Given this list of marker genes COL3A1, OLFML2B, COL1A2, COL5A1, FAP, LUM, LOX, SUGCT, COPZ2, COL5A2, AEBP1, SNAI2, NUAK1, LOXL2, COL6A3, GREM1, EPYC, COL11A1 (NCBI Gene Id 317718), COMP, PCOLCE, COL1A1, CRISPLD2, C1QTNF3, MFAP5, EDNRA, RAB31, MMP2, SPOCK1, CTSK, TMEM158, GLT8D2 (NCBI Gene Id 83468), SERPINF1, BGN, MXRA5, MMP11 (matrix metallopeptidase 11), SPARC, FN1, POSTN, THY1, COL10A1, NID2, RCN3, COL6A2, TIMP3, TNFAIP6, ITGBL1, PRRX1, CDH11, ACTA2, PLAU, THBS2, FBN1, ADAM12, LGALS1, LRRC15, PDGFRB, NTM, SULF1, VCAN, SFRP4, DCN, NOX4, ASPN, INHBA, here is a description of the gene set: studied in species Homo sapiens Human Gene Set: ANASTASSIOU_MULTICANCER_INVASIVENESS_SIGNATURE from publication Anastassiou D, Rumjantseva V, Cheng W, Huang J, Canoll PD, Yamashiro DJ, Kandel JJ (PMID 22208948) BACKGROUND: The biological mechanisms underlying cancer cell motility and invasiveness remain unclear, although it has been hypothesized that they involve some type of epithelial-mesenchymal transition (EMT). METHODS: We used xenograft models of human cancer cells in immunocompromised mice, profiling the harvested tumors separately with species-specific probes and computationally analyzing the results. RESULTS: Here we show that human cancer cells express in vivo a precise multi-cancer invasion-associated gene expression signature that prominently includes many EMT markers, among them the transcription factor Slug, fibronectin, and alpha-SMA. We found that human, but not mouse, cells express the signature and Slug is the only upregulated EMT-inducing transcription factor. The signature is also present in samples from many publicly available cancer gene expression datasets, suggesting that it is produced by the cancer cells themselves in multiple cancer types, including nonepithelial cancers such as neuroblastoma. Furthermore, we found that the presence of the signature in human xenografted cells was associated with a downregulation of adipocyte markers in the mouse tissue adjacent to the invasive tumor, suggesting that the signature is triggered by contextual microenvironmental interactions when the cancer cells encounter adipocytes, as previously reported. CONCLUSIONS: The known, precise and consistent gene composition of this cancer mesenchymal transition signature, particularly when combined with simultaneous analysis of the adjacent microenvironment, provides unique opportunities for shedding light on the underlying mechanisms of cancer invasiveness as well as identifying potential diagnostic markers and targets for metastasis-inhibiting therapeutics. Invasiveness signature resulting from cancer cell/microenvironment interaction.